Given this list of marker genes SLC26A2, EXTL3, TRPV4 (NCBI Gene Id 8098), PLCB3, ACP5, TMEM53, here is a description of the gene set: studied in species Homo sapiens An increase in the vertical distance between adjacent vertebral bodies, observed as an increase in the intervertebral disk space. Human Gene Set: HP_INCREASED_INTERVERTEBRAL_SPACE Increased intervertebral space